Given this list of marker genes ADPRS (ADP-ribosylserine hydrolase), MUTYH, FZD9, MIR485, MIR101-1, SLC25A4, BOK (NCBI Gene Id 84558), BIRC3, NUPR1, CASP8, RNF31 (ring finger protein 31), FADD, NOL3, PELI1, MIR221, RIPK1, MIR22, ARHGEF2, YBX3 (Y-box binding protein 3), MIR214, MIR223, BIRC2, RBCK1, CAV1, here is a description of the gene set: Any process that decreases the frequency, rate or extent of programmed necrotic cell death. studied in species Homo sapiens Human Gene Set: GOBP_NEGATIVE_REGULATION_OF_PROGRAMMED_NECROTIC_CELL_DEATH